Given this list of marker genes COL10A1 (NCBI Gene Id 93042), RECQL4, CTC1 (CST telomere replication complex component 1), SBDS, KIF22, ACP5, DNAJC21, MMP13, ANAPC1, SRP54, CENPE, COL2A1, here is a description of the gene set: species: Homo sapiens Human Gene Set: HP_METAPHYSEAL_SCLEROSIS Abnormally increased density of metaphyseal bone. Metaphyseal sclerosis